The following is a description of a gene set: species: Homo sapiens Human Gene Set: GOBP_MAINTENANCE_OF_SYNAPSE_STRUCTURE A process that preserves the structural organistation and orientation of a synaptic cellular component such as the synaptic cytoskeleton and molecular scaffolds., and this is the list of marker genes: PPFIA2, ARF6, DCTN1, BSN, SYNGAP1, OPHN1, PLXNA4, SORT1, ITGB3, PRICKLE1, CSMD2, ERC1, C1QL1, PCLO, APPL1, GRN, GIT1, RIMS2, RAPSN, ERC2, CBLN1, CHCHD10, CBLN2, SHANK1, RIMS1, SDF4, RIMS3, RAB3A, ADGRB3, DLG1, CBLN3